The following is a description of a gene set: Human Gene Set: GSE15330_GRANULOCYTE_MONOCYTE_PROGENITOR_VS_PRO_BCELL_UP studied in species Homo sapiens from publication Ng SY, Yoshida T, Zhang J, Georgopoulos K (PMID 19345118) Regulation of lineage potential and transcriptional priming by Ikaros. New insight is provided into a bivalent regulation of lineage priming in the HSC and its lympho-myeloid restricted progeny the LMPP by the lymphoid lineage-determining factor Ikaros Whereas Ikaros is responsible for the activation of a cascade of lymphoid expression programs and for the establishment of lymphoid potential from the HSC to the LMPP it is also responsible for the repression of stem cell and erythroid genetic programs that are incompatible with further lineage restrictions emanating from the LMPP Genes up-regulated in granulo-monocyte progenitors versus pro-B lymphocytes., and this is the list of marker genes: CUL4A, TAF11, SLC7A4, NSMCE2, CZIB, INTS7, ATP5PB, HSPBP1, VWA8, SMIM11, IL9R, PSPC1, CSTF1, EMC6, MAPRE2, CDK2, MLLT1, NOL7, MYOM2, EGLN3, GTF3C4, ORC1, CENPB, PRAF2, LYPLA1, MTBP, RNASEH2C, ZNF296, ATP1A1, NBN, SOD2, EBPL, PYCR2, MTIF2, CPPED1, TARS1, ATG9B, NFS1, CHAC2, MTERF4, ARPP19, TP53RK, TMEM39A, PTPMT1, WDR46, SFRP5, CTR9, NDUFS4, C16orf74, SH3BP2, GSS (NCBI Gene Id 2937), ALCAM, SENP3, BORCS5, STK3, PIGB, IMMP2L, YWHAQ, BLMH, LXN, TRMT2A, PRDX2, LPCAT1, N4BP3 (NEDD4 binding protein 3), RPP40, INTS14, FANCE, POLR1C, LAMB1 (laminin subunit beta 1), STK16, PSMB1 (proteasome 20S subunit beta 1), COPS2, STT3A, TPRKB, INTS9, PEX19, MBD4, GORASP1, TNFRSF13C, RORC, MRPL46, BCKDHB, GAS8, REEP1, NLGN2, GATAD2A, SMN1, C15orf40, SENP1, SAP18, ARL16, ATP5MC3, VTI1A, SDHA, LHX5, GBE1, HMGXB4, NPNT, UQCRC1, SERPINE2, DBNL, POMGNT1, NIP7, SLC12A2, GTF3C5, INTS8, PFN1, GTF2H1, TUBB4B, GPR89B, ADSS2, RACGAP1, ADGRA3, BZW2, TUSC3, IL12RB1, NCAPH2, TMEM47, UTP18, ALG5, GALK2, SLX9, SPRYD7, MYO5A, FAM86B2, EIF2S3, ZNF48, CBR4, RNH1, HSBP1, SF3B3, ADAM10, TCOF1, DUSP7, TPST1, TYW1, TMA16, NADK, MTX1, C1D, RCC2, TNFSF9, GNL3, ST7, ARMC10, C1QTNF12, PLPP1, UROD, RBM19, GPN1 (GPN-loop GTPase 1), IMPA1, HNRNPC, TERT, DRG1, ERGIC2, FEM1B, NUP88, SURF2, ZCCHC10, WRAP53, KIFC1, ACLY, CCDC107, KRCC1, RPGRIP1, RTCA, TNFRSF21 (NCBI Gene Id 51323), FAM89A, PDE6D, CHST2, LRP8, KNSTRN, UTP25, TSSK3, TBCD, FAM216A, GLRX2, RPP14, LDAH, SNF8, GTPBP4 (NCBI Gene Id 23560), ACBD6, SAAL1, CUTC, AMACR, GLE1, EEF1D, RRP1, MED21, EIF4E, CDKN2AIPNL, HDAC2, MFN2, RNF26, CFAP20, MRPL54, NAT1, NTMT1, LMNB1